The following is a description of a gene set: studied in species Mus musculus Catalysis of the hydrolysis of any carbon-nitrogen bond, C-N, with the exception of peptide bonds. Mouse Gene Set: GOMF_HYDROLASE_ACTIVITY_ACTING_ON_CARBON_NITROGEN_BUT_NOT_PEPTIDE_BONDS, and this is the list of marker genes: Arg1, Dhodh, Mblac2, Cdadc1, Afmid (arylformamidase), Acy1, Adal, Pglyrp2, Hint1, Mthfd2l, Asrgl1, Acer2, Ampd2, Apobec1, Aicda, Ndst1 (N-deacetylase/N-sulfotransferase (heparan glucosaminyl) 1), Hdac11, Klk1b4, Hdac6, Ndst4, Btd (biotinidase), Oplah, Klk1b26, Pglyrp3, Hint2, Crmp1, Klk1, Naaa, Dclre1b, Gls, Hdac1, Sirt5, Asah2, Ddah1 (dimethylarginine dimethylaminohydrolase 1), Cat, Rida, Dclre1a, Dpep1, Lacc1, Hdac9, Acr, Dctd, Cda, Ndst2, Agmat, Nit1, Padi2, Adat1, Nadsyn1, Padi1, Padi3, Hdac8, Gnpda1, Apobec3, Gnpda2, Aspa, Dpysl2, Ntaq1, Pm20d2, Adat2 (NCBI Gene Id 66757), Gls2, Pm20d1, Amdhd1 (NCBI Gene Id 71761), Adarb1, Padi6, Hdac10, Adad2, Pglyrp1, Mthfd1, Ada, Dpys, Gda, Amdhd2, Allc, Pigl, Naalad2, Klk1b16, Zbp1, Apobec2, Acer1, Adad1, Hdac3, Adar, Arg2, Vnn1, Urah, Dpysl3, Park7, Hdac4, Klk1b21, Vnn3, Ngly1, Klk1b5, Klk1b22, Klk1b11, Dpysl5, Faah, Klk1b9, Acy3, Klk1b27, Klk1b8, Pglyrp4, Klk1b1, Gch1, Hdac2, Ampd1, Tgm2, Adat3, Cad, Ndst3, Sirt2, Sirt1, Aspg, Pdf, Dpysl4, Adarb2, Gchfr, Pycr3, Mthfd2, Hint3, Ampd3, Ddah2, Fhit, Padi4, Ntan1, Hdac5, Upb1, Hdac7 (histone deacetylase 7), Klk1b3, Sirt4, Asah1, Atic, Klk1b24, Nit2, Acer3, Aga (aspartylglucosaminidase)